Given this list of marker genes Mpc2, Myc, Slc5a8, Slc16a3, Mpc1, Slc16a11, Slc16a7, Slc16a1, here is a description of the gene set: The directed movement of pyruvate into, out of or within a cell, or between cells, by means of some agent such as a transporter or pore. Mouse Gene Set: GOBP_PYRUVATE_TRANSPORT studied in species Mus musculus